The following is a description of a gene set: Any process that modulates the rate, frequency, or extent of the process whose specific outcome is the progression of a chondrocyte over time, from its commitment to its mature state. Chondrocyte development does not include the steps involved in committing a chondroblast to a chondrocyte fate. Mouse Gene Set: GOBP_REGULATION_OF_CHONDROCYTE_DEVELOPMENT studied in species Mus musculus, and this is the list of marker genes: Rflnb, Hoxd11, Smad7, Rflna, Hoxa11 (NCBI Gene Id 15396), Pthlh, Axin2